The following is a description of a gene set: Any process that modulates the frequency, rate or extent of meiotic cell cycle phase transition. Mouse Gene Set: GOBP_REGULATION_OF_MEIOTIC_CELL_CYCLE_PHASE_TRANSITION species: Mus musculus, and this is the list of marker genes: Ttk, Chfr, Zwint, Mos, Pkmyt1, Cdc25c, Mapk15, Ovol1, Stk35, Knl1, Cdc25a, Usp17le, Cdc25b, Pdik1l